Given this list of marker genes RSAD2, BAZ1B, GARS1, ID2, VCAN, FJX1, SUPT7L, IPO9, SNHG12 (small nucleolar RNA host gene 12), NUDCD1, GPSM1, CCT8, CUEDC2, WDHD1, CCZ1, GAPDH, ARNT2, E2F1, MCM7, ZNF317, CSE1L, GAD1, NAA50, QDPR, FKBP7, CENPJ, C19orf48P, POT1, CHI3L1, PCSK6, QTRT2, SUPV3L1 (NCBI Gene Id 6832), PHF5A, DSCC1, IQGAP3, DPY19L1, SIKE1 (NCBI Gene Id 80143), TXNDC12, HDGFL3, POSTN, LSM6, ZWILCH, CENPK, ZNF678, CRISPLD2, GATA6, ADNP2, ROBO1, LMNB1, PSMD14, DDHD1, DEPDC1, DEPP1, PRMT3, NCAPD3, RIF1, CENPN, IFI44, BUB3, TPI1, HOXA10, TNFRSF9, AATF, PWP1, AKIP1, PHF14, TMEM168, MSH2, UBXN4, BRIX1, TRUB1, NTRK2, ZNF280C, GBP4, MTFR2 (mitochondrial fission regulator 2), ARID2, MAGOHB, LIN9, CPT1C, BFAR, TTK, PINX1, PRNP, CHST14, NDC1, RAI14, UTP14A, TMEM200C, NF1, MTRR, UBFD1, PILRA, RECQL, TUBGCP4, LMAN1, FN1, C5orf34, SFXN1, HOMER3, ENOPH1, SHANK3, SLC39A6, QKI, GZMB, GAPDHP73, HNRNPAB, CEP152, ORC2, MCPH1-DT, EIF3B, SGO2, PKP4, DSN1, SMAD1-AS2, ASAP1, ZC3H11A, PPP3R1, ZNF140, NDC80, DDX39A, CHEK2, PLAGL2, ZNF718, NME1, LDHA, SPG21, THAP9-AS1, RBMX, PMS2, BOD1, AATBC, RACGAP1, PSMB3, IFI44L, NEDD1, ZNF614, HAVCR2, EXOSC5, CDKN3, CHROMR, TWNK (NCBI Gene Id 60508), ANO6, VANGL2, MAP2K4, TSFM, PTTG3P, TFCP2 (NCBI Gene Id 7024), SSBP1, UBE2T, RAD54B, PAICS, DNA2, ANKRD29, BEX3, ZDBF2, UQCC2, CHCHD3 (NCBI Gene Id 54927), SDC2, HIC2, ZC3H8, AGO3, HELLS, FASLG, WAC-AS1, STARD3NL, MRPL32 (mitochondrial ribosomal protein L32), TM6SF1, SBF2-AS1, NAP1L1, PGAP1, ADSL, ERCC6L, TARS1, MTHFD1L, TTI1, IL15, COLGALT1, HSP90B1, ZNF431, EIF3M, CBX2, PA2G4, SLC9A7, RPS24, MAGT1, FASTKD3, SUB1, PAN2, FLAD1, AXL, ANLN, FXR1, CBX3, PDRG1, FKBP4 (NCBI Gene Id 2288, FKBP prolyl isomerase 4), PPIA (peptidylprolyl isomerase A), MTHFD2L, UBE2F, BRCA1, FZD7, NOL8, FNTA, ZNF561-AS1, ZNF37A, RPS21, CAD, TTLL4, EIF2B1, ARHGAP11A, ABCE1, SEH1L, TNPO1, PLPBP, MRPS17, SLC25A40, MIS18A, U2SURP, AFAP1, EDRF1, CTSC, ADAR, MTHFD2, DDX11, NOC3L, TMPO, RASSF4, CCND2 (cyclin D2), OIP5, CALU, NRXN1, CCT3, CXCL9, STMN1, IFRD1, TMED4, RINT1, ARMC1, ATP6V1B2, SLC7A5, WDR4, JMJD4 (NCBI Gene Id 65094), CCT6P3, RO60, TRAM2, GOSR2, MICAL2, DTL, ZNF267, UBE2C, ATP11C, CLCC1, MGME1 (NCBI Gene Id 92667), CXCL11, WBP11, VPS54, RBFOX2, TLE1, MYNN, CNTNAP2, INPP4A, ERVK3-1, AIDA, LSM8, TRPM7, PTCD3, HERC2P9, SF3B1, ZKSCAN3, COL6A3, NONO, ASB9, NSD2, ZNF45, DNAJA3, RCL1, TRIAP1, WDR75, PMS1, ZNF234, FRRS1, TICAM2, ALG6, OLFM1, RRM2, TSEN15, GRSF1, UTP18, ASPM, SCAI, MCM3, KLHL42, CDCA2, CSTF1, POLQ, ORC6, SNX5, RFC4, RAD21, MMD, SSTR2, URB2, PAIP1, ABCF2, KPNB1 (NCBI Gene Id 3837), ZCRB1, CHAF1A, SULF1, NT5M, C1orf131, ZNF473, LRPAP1, USP31, RPL35A, CAV1, KANSL2, ZNF121, C18orf21, CYC1, HPRT1, DPYSL2, BID, TTF2, NRAS, HACD3, C6orf141, ADAM22, KNSTRN, RBBP4, PTGS2, DNAAF9, CAND1, LMBR1, PRRX1, HIP1, FPR3, RFC5, C1QBP, SLBP, NNT, HEATR1, NUP205, BRD4, KCNJ8, MAP3K20 (mitogen-activated protein kinase kinase kinase 20), CCDC77, NUAK1, MORC4, DIABLO, MED21, EPHB2, ALYREF, USP14, HSPE1, TCF12, KIF18B, LHFPL2, TNFSF4, COL5A2, MARS1, SF3A3, RPS6KB1, ZNF117, DSG2, XAF1, SNHG6 (small nucleolar RNA host gene 6), MINPP1, RSKR (ribosomal protein S6 kinase related), LMNB2 (lamin B2), U2AF1, TIGAR, UBXN2B, DHX15, DDX18, ZNF532, LINC00839, SMARCAD1, PBK, FSCN1, CCNE2, SLC44A1, ZNF260, MCCC2, ELOC, NUP58, CENPA, ZNF26, TMA16, MCM6, NUDT1, NFE2L3, RNF4, DPY19L4, PAXIP1, KIF11, OSBPL1A, TM7SF3, MTMR4, MBTPS2, RPL30, BTG3, LGALS1, OLA1, ANAPC1, FBXO22, GINS1, SAC3D1, GHR, MKLN1, RILPL1, FBL, PMP22, FASTKD2 (NCBI Gene Id 22868), RCN2, COL1A2, GPSM2, FARP2, HMG20A, CCT4, ZNF567, POLG2, KITLG, POLR2D, CASK, C3AR1, EME1, ALKBH2, DEPDC1B, RCHY1, XPOT, LAMP2, LHX2, ANAPC7, ENO1, OSGEPL1, SH2B3, RFC1 (replication factor C subunit 1), C11orf96, NEDD4, ORC3, CKS1B, ANAPC5, RANBP2, TMEM33, BUB1B, UBE2L3, EIF2AK4, PSMA2, ST20, NUP160, MCMBP, DOCK4, PIGW, SSX2IP, IFNG, NOP2, ARHGAP8, CCNG1, RPS15A, AJUBA (NCBI Gene Id 84962), ASCC3, DCAF6 (NCBI Gene Id 55827), CCT6A, GBP5, FAM111A-DT, URI1, MYC, MLLT11, FOXO6 (forkhead box O6), GNPDA1, SLC25A36, MAT2A, EGLN1, MIR17HG, G3BP1, FOXRED2, ERICH1, DBF4, SLC25A32, CD80, PRR11, MMP3, ZFR, SRP72, GTF3C4, TMEM209, HOXC9, ICE2, TK1, HNRNPD, EPB41L3, MIEF1, SOCS5, YARS2, NPL, KREMEN2, PMAIP1, EIF5A2, UBA2, GMPS, FUT10, GPATCH2, B3GALT6, GAS5, ALDH8A1, PSMB2, VASH2, RCC2, IRF6, ZNF195, FCGR2A, LINC03026, SNAP47, CCSAP, FRMD4A, RBL1, MNDA, FGF2, ADAM12, GGCT, BMPR1A, HAUS1, ARPP19, AKIRIN2, SLC39A14, CRLS1, KIF2C, PFDN4, NAA25, ZSCAN32, PSMA7, SIGLEC1, PLA2G4C, DMD, RPN2, RBM15, SPINDOC, PPRC1, NEIL3, IFIT3, NPM1, ZBTB24, EIF3J, FKBP14 (FKBP prolyl isomerase 14), F2R, CSTF3, TNIP3, GASK1B, PTTG1, PIMREG, METTL21A, SKP2, ACTMAP, ZNF207, MED28, CBX5, CIAO2A, SYNPO2, FAF2, FGD6, FNDC3B (NCBI Gene Id 64778), CALD1, YWHAQ, PRIM1, B3GALNT2, TOMM40, RGS4, GAS2L3, LAP3, PDCD5, CSAG3, RAD51, CPSF3, MPZL1, PGK1, THBS2, METTL1, CD14, CCDC18, LINC00622, MCM2, SOCS2 (NCBI Gene Id 8835), FCGR1A, RSRC1, CCDC150, GBP1, ILF2, TYROBP, B4GALT6, NOPCHAP1, COL4A2, GARS1-DT, TPX2, ADAMTS2, YARS1, MRPL42, KIF23, PRF1, CS, ANKRD46, DCTD, UTP25, CSAD, RAD1, CDK1, LSM5, RANBP1, C8orf33, TM2D2, DHX33, SRC, NPC1, VRK2, CNIH4, PSAT1, ZNF286A, STRAP, CLEC4E, GTF3C3 (NCBI Gene Id 9330), ZNF81, CD200, CDK12, PNO1, INTS13, SMC2, IDH1, C1QB, GOLT1B, POLR2B, RAD54L, TGIF2, MTR, CCDC59, MEMO1, TYMS, GTPBP10, TAF5, HOXC6, PPAT, DLGAP5, LLPH, MAPRE1, CHTOP, TDO2, KLHL5, CASP6, CCL3, GJA1, PRIM2, CEP170, GALNT11, NDUFAF6 (NCBI Gene Id 137682), FMNL2, E2F3, NIFK, SMIM10L1, HSPA14, RMI2, CPOX, IKBIP, MIR3682, YAF2, FRAS1, PTBP2, GLS, MANEAL, DIAPH3, AHCY, COPZ1, MTPAP, SPAG5, PITPNB, CAPRIN1, TRMT61B, WDR43, PSMA4, NTAN1, NTPCR, CENPI, LRPPRC, FBN1, ECT2, TNFAIP6, SEC61A2, STAT1, CENPQ, RCCD1, CLASP1, GART, CAMKK2, PUS7L, ZNF805, NOP16, SNRPF, NLN, TRAP1, KIF15, CDC7, ISG20L2, NUP107, KCNMA1, SASS6, MELK, NCAPG, MFF, CTPS1, ZNRF3, E2F6, MFSD14A, SPOPL, ZNF547, HMGXB4, AMOTL1, HMGB2, TAF4B, EIF1AX, MALSU1, DRAM1, DHTKD1, ADH5, COL5A1, NPM1P22, ATP2C1, CCNF, CXCL10, RPL6, ANKRD22, CENPU, INTS7, MASTL, FCER1G, ENSG00000187951, BLMH, NFYB, XPO1, PRR5, SKA3, CCL13, SETMAR, GCA, RNF213, CTSL, CENPO, SENP6, FLVCR1, SLC25A13, NEK2, COL4A1, AK2, THOC1, FIGNL1, RFC3, SEMA6A, SRSF2, KIF20A, TFAM, MMP12, PTEN, TIPIN, PRPF40A, TFRC, IPO5, TGS1, DARS1, CCL2, SPIN1, FCGR3B, CYCS, FANCG, ZNF131, ZNG1A, AK3P3, TIMM10, TUG1, APMAP, SACS, IL15RA (interleukin 15 receptor subunit alpha), MIR3685, AGK, DKC1, FGFR1OP2, UBE2Z, TRIM24, CACNA2D1, CHAF1B, RBM34, MMP1, THUMPD2, HNRNPM, CD274, PRC1, NUCKS1, RIDA, CCT2, COA1, FUBP1 (far upstream element binding protein 1), SCYL2, KLHL12, COL22A1, TIMM23B, RHEBP1, NUDT3, COL1A1, CDC25C, ZBTB2, CPSF4, NEMP1, CEP55, MSH6, HNRNPU, TNFSF15 (NCBI Gene Id 9966), TMEM97, AIRIM (NCBI Gene Id 54955), POLA1, TBK1, TIMMDC1, TMEM39A, TOMM70, NREP, MARS2, RHNO1, NUF2, ZNF618, NUSAP1, BCL2L11, DPH5, WDR3, ZBED3, NXT1, UHRF1, MAPKAPK5, NOL11, DDX60L (DExD/H-box 60 like), SLC30A6, ARHGAP11B (NCBI Gene Id 89839), PCDH17, KLHL23, EIF2S2, DTYMK, CCNA2, HNRNPA1 (NCBI Gene Id 780920), AIMP1, ATAD2, SCNN1G, PLPP4, CEP135, UQCC6, PARAIL, NCAPH, NAV1, MYO19, POP1, KHSRP, LINC01943, OSTC (oligosaccharyltransferase complex non-catalytic subunit), SHMT2, CENPL, SND1, CKAP2, GREM1, FEN1, NCBP1, FAS, LINC00173, GABPB1, TICRR, DDX47, SUMO1, PLXNA1, ADAM23, SMARCE1, ANGEL2 (NCBI Gene Id 90806), CHEK1, TANK, SNHG15, FUS, ZNF100, DLEU2, ADIPOR2, TOPBP1, LAMA4, MRPL9, CCAR1, GRPEL1 (GrpE like 1, mitochondrial), SNRPE, THY1, GLMP, CCN3, POLE2, EIF2AK2, CENPH, PSMC3IP, TRA2B, NPNT, RNPS1, SNRPG, RPRD1A, CDCA5, DONSON, PABPC4L, TMEM38B, LUC7L2, ASNS, GSTO1, RBMX2, SRSF3, STAR, XRCC6, MCM10, RNF139-DT, CDC25A, FBXO28, GCFC2, ATR, ZZZ3, YWHAG, VPS53, SNX10, MTRFR, DENR, MYDGF, CHCHD4, SUZ12, COA7, NAA15, U2AF2, ZNF124, KIF1B, RPL37A, HAUS6, AP3M1, EEF1E1, ACTA2, SRSF7 (NCBI Gene Id 87459), DUT, PAXBP1, OAS3, SLC39A10, KATNBL1, RIPK2, NOM1, TARBP1, RCN1, TOR1A, ENY2 (NCBI Gene Id 56943), TPT1-AS1, METTL5, SERPINE1, STX16, MCM4, CEP78, MS4A4A, PRMT1, MRPL3, STX6, C10orf88, PATL1, POMGNT1, CDC27, NOP56, CCDC14, PLK4, MAILR, TIPRL, AEN, IGSF6, ARHGEF40, ELAVL1, MANEA, AGO2, RHOT1, RBBP9, CENPE, SPDL1, CCR1, POLR2H, EXT1, DUSP12, BGN, PXMP2, HOXA3, NDUFAF4, ETV6, PNN, DDX52, NCBP2, BRIP1, MTX2, CCNB2, MSR1, NUP37, BIRC5, CCNT1, ITPR2-AS1, ORC5, DDX55, CNPY2, ZNF697, SMARCA4, UPF3B, SLCO5A1, RAD51AP1, DNAJC9, PRIMPOL, NUP155, FAM171A1, PSRC1, KIF14, NCL, HNRNPH1 (heterogeneous nuclear ribonucleoprotein H1), MBTD1, NUP35, NAPEPLD, ITGB3BP, RPE, PIGM, ZNF138, FANCM, ICAM1, ADNP, DHFR, SDCCAG8, SCD5, TOR1AIP2, SPATS2, TIA1, AGPAT3, RBM4, SNHG16, SRSF10, PARP12, CISD2, PANK1, SF3B4, RABGGTB, CDC6, L3MBTL4, CHN1, LINC00665, RBBP8, COL8A1, MPHOSPH9, TCF3, SLC16A1, SPARC, RPS19, FAM83B, ZGRF1, PDHA1, IMPACT, OTULIN, SELENOI, GZMA, DESI1, PALB2, UBE3A, RNASEH2A, CCL4, C4orf46, ZNF780A, DDX60, FXN, VEZT, CBX1, ADO, MRM2, SRSF1, MCM8 (NCBI Gene Id 84515), ELP3, POMK, TP63, NOP58, AP3M2, CDC45 (NCBI Gene Id 8319), KIF18A, RPS15, ATF4, BRI3BP, ADA, DDX21, ARF3, SOX6, ANGPT2, SOX4, R3HDM1, TAF1A, GUCY1B1, ZNF562, ARK2C (arkadia (RNF111) C-terminal like ring finger ubiquitin ligase 2C), CKS2, PRKDC, HJURP (Holliday junction recognition protein), DUXAP8, TOP2A, TIMELESS, CNOT2, CCL8, EPRS1, ARL6IP6, KIF20B, DEGS1, RAN, AIMP2, TREX2, XRCC4, ZNF92, TBC1D24, CCNB1, PHB1P19, PCOLCE2, COL3A1, LTV1, COL15A1, ATIC, RBIS, INHBA, ACSL4, NID1, CDK4, PHGDH, GPR89B, PCDH18, COL10A1, XRCC5, GFM1, PSMA1, CDCA7 (cell division cycle associated 7), DEK, GRB10, MRPL19, CNOT9, ANKLE2, INTS8, C15orf61, PTRH2, RAD18, GMNN, XPO5, SLC30A7, NUP62, PCLAF, CCDC28B, EIF4E2, APBB2, DERL1, UTP6, NUTM2A-AS1, MARK1, PNPT1, INTS12, SMG1, ZNF281, GTF2F2, RRP15, LSM12, CCDC71L, SLC1A3, POLR1A, ETNK1, RBPJ, CEP192, FAM200A, ERI1, ENTREP3, ESCO2, POGLUT1, NDUFB9, UQCRH, EXO1, RPL31, ZNF512, RTKN, PLAU, MTF2, NMD3, ILF3, CMSS1, SENP1, CAMTA1, EMILIN2, LYAR, CUL1, NUP43, SMIM30, TMEM69, NCAPG2, NBN, ASB3, TRIP6, PDSS1, DNM1L, MTERF3, LINC01094, KCTD3, PSMG1, RPL22, SMC1A, MRPL24, CTDSPL2, NUP42, LARS1, GPR137B, SLC35F2, SEPHS1, MSL1, MRPS23, SLC5A6, TCTN3, SNRPD1, HNRNPA2B1, SCML1, FKBP1A, MKKS, C18orf54, RRP1B, METTL8, POLR1B, PCNA, PROSER1, USP18, NBPF9, RNU6-73P, BRAP, TET1, THAP2, LRRC40, SLC25A17, PAPSS2, ZNF146, YWHAH, HMMR, MARCKSL1, GNAS-AS1, POGLUT2, KNTC1, LCTL, GORAB, S100PBP, SCML2, SUMO2, YEATS2, UBE2G2, PIK3C2A, AHCTF1, MND1, NUP54, TWSG1, SNRPA, UBE2E3, RRM1, DENND1A, KIF4A, AKT3, PUS1, ADORA3, KNL1 (NCBI Gene Id 57082), FBXO5, NSD3, LUC7L3, XG, FOXM1, PARPBP, FKBP5, EFNB2, HNRNPC, SNHG29, ZNF112, PRLR, RNASEH1 (ribonuclease H1), PPA1, ITGB6, ZNF367, CD163, SNHG8, FASTKD1, BRCA2, EARS2, SARNP, GINS3, PDGFRL, SMC4, TMEM167A (NCBI Gene Id 153339), NUP133, UBA5, CIP2A, UNG (NCBI Gene Id 7374), PFDN2, STAMBP, SNHG26, DNAJB6, GTPBP4, DOCK7, GZMH, PSPH, ANKIB1, SUV39H2 (SUV39H2 histone lysine methyltransferase), COPS2, HNRNPLL, PRRC2C, TMEM70, RRN3 (RRN3 homolog, RNA polymerase I transcription factor), ZWINT, UCHL5, SPMIP1, ITGA1, ZNF519, UCK2, CYRIB, LOC102724701, NUP85, CKAP4, EPHB4, KNOP1 (lysine rich nucleolar protein 1, NCBI Gene Id 400506), KPNA2, FBH1, CPSF6, ME2, TAF1D, SOCS1, SGO1, MKI67, QSER1, BZW2, IMMT, COL27A1, GNLY, IARS1, TIMM21, TBCE, CACYBP, UBE3C, KICS2, TDG, DNAJC14, BUB1, DNAJC2, APOC1, MAD2L1, TMEFF1, NOLC1, PAWR, NDUFAF5, ZNF587, ATL2, C2orf69, UMPS, STK3, PHB1, HDAC2, ZNF557, EZH2, TXNL4A, CENPF, MTCL1, NIPSNAP1, DDX50 (NCBI Gene Id 79009), LRR1, ABRACL, GINS2, WRN, FANCI, LAMB1, TUBB, FEZ2, TFB2M, GXYLT1, FAM72C, ITGAV, ZC3H15 (NCBI Gene Id 55854), GALNT2, YBX1, ZFAS1, PM20D2, TSR1, RPLP0, OTUD6B, CKAP5, ZNF84, GPN3, MRPL30, CASP8AP2, RSL1D1, PLA2G7, PPIF, HSPD1, ZIC2, PUS7, C11orf58, TNFRSF10B, RAD51C, WDSUB1, H2AZ1, RBM28, FERMT1, ARL5A (NCBI Gene Id 26225), LAMC1, RIGI, UBAP2L, ATP5MC3, GTF2H3, AURKA, SGIP1, ARHGEF10, IFIH1, ATF5, PTPN14, here is a description of the gene set: Genes up-regulated in nasopharyngeal carcinoma (NPC) compared to the normal tissue. Human Gene Set: DODD_NASOPHARYNGEAL_CARCINOMA_UP from publication Dodd LE, Sengupta S, Chen IH, den Boon JA, Cheng YJ, Westra W, Newton MA, Mittl BF, McShane L, Chen CJ, Ahlquist P, Hildesheim A (PMID 17119049) Polymorphisms in nitrosamine metabolism, DNA repair, and immune response genes have been associated with nasopharyngeal carcinoma (NPC). Studies have suggested chromosomal regions involved in NPC. To shed light on NPC etiology, we evaluated host gene expression patterns in 31 NPC and 10 normal nasopharyngeal tissue specimens using the Affymetrix Human Genome U133 Plus 2.0 Array. We focused on genes in five a priori biological pathways and chromosomal locations. Rates of differential expression within these prespecified lists and overall were tested using a bootstrap method. Differential expression was observed for 7.6% of probe sets overall. Elevations in rate of differential expression were observed within the DNA repair (13.7%; P = 0.01) and nitrosamine metabolism (17.5%; P = 0.04) pathways. Differentially expressed probe sets within the DNA repair pathway were consistently overexpressed (93%), with strong effects observed for PRKDC, PCNA, and CHEK1. Differentially expressed probe sets within the nitrosamine metabolism pathway were consistently underexpressed (100%), with strong effects observed for NQ01, CYP2B6, and CYP2E1. No significant evidence of increases in rate of differential expression was seen within the immune/inflammatory pathway. A significant elevation in rate of differential expression was noted for chromosome 4p15.1-4q12 (13.0%; P = 0.04); both overexpression and underexpression were evident (38% and 62%, respectively). An elevation in the rate of differential expression on chromosome 14q32 was observed (11.3%; P = 0.06) with a consistent pattern of gene underexpression (100%; P < 0.0001). These effects were similar when excluding late-stage tumors. Our results suggest that nitrosamine activation and DNA repair are important in NPC. The consistent down-regulation of expression on chromosome 14q32 suggests loss of heterozygosity in this region. studied in species Homo sapiens